Given this list of marker genes Habp4, Gemin2, Zpr1, Gemin7, Gemin8, Gemin6-ps, Gemin5, Gemin6, Npat, Ddx20, Smn1 (NCBI Gene Id 20595), here is a description of the gene set: Mouse Gene Set: GOCC_GEMINI_OF_CAJAL_BODIES Nuclear bodies frequently found near or associated with Cajal bodies (also called coiled bodies or CBs). Gemini of coiled bodies, or 'gems', are similar in size and shape to CBs, and often indistinguishable under the microscope. Unlike CBs, gems do not contain small nuclear ribonucleoproteins (snRNPs); they contain a protein called survivor of motor neurons (SMN) whose function relates to snRNP biogenesis. Gems are believed to assist CBs in snRNP biogenesis, and to play a role in the etiology of spinal muscular atrophy (SMA). species: Mus musculus